The following is a description of a gene set: Any process that activates or increases the frequency, rate or extent of the import of the hexose monosaccharide glucose into a cell or organelle. species: Mus musculus Mouse Gene Set: GOBP_POSITIVE_REGULATION_OF_D_GLUCOSE_IMPORT, and this is the list of marker genes: Mef2a, Klf15, Igf1, Adipoq, Repin1, Fgf15, C1qtnf2, Pth, Rnasel, Prkcd, Akt1 (thymoma viral proto-oncogene 1), Tert, Sorbs1, Erbb4, Rap1a, C2cd5, Insr, Rhoq, Rasa1, Opn3, Ins1, Prkci, Capn10, Ins2, Appl1, Pou4f2, Mapk14, Oga, Gpc3, Osbpl8 (NCBI Gene Id 319994), C1qtnf12, Irs2, Erbb3, Slc1a2, Adipor2, Akt2, Ptpn11, Ocln, Fgf21, Itln1, Nfe2l2 (NCBI Gene Id 98874), Irs1, Crebl2, Erfe, Mfn2